Given this list of marker genes Chst2 (NCBI Gene Id 54371), Prokr2, Trim33, Ccl25, Nedd4, Acvr2a, Galnt7, Maml1, St3gal2, Zrsr2, Krtap4-2, Elavl3, Cabp5, Ints8, Ccr1, Stimate, Hmmr, Ttll3, Srf, Ppp1r9b, Nemp1, Zfp462 (zinc finger protein 462), Cd37, Galnt13, Apex2, Slc39a13, Cacna2d2, Clip3, Zfp687, Ahnak, Adtrp, Arb2a, Stk35, Nxph1, Efnb1, 4921517D22Rik, Pik3ca, Dennd4a, here is a description of the gene set: from publication Chen Y, Wang X (PMID 31504780) Genes predicted to be targets of miRBase v22 microRNA mmu_miR_6928_5p in miRDB v6.0 with MirTarget v4 prediction scores > 80 (high confidence targets). Mouse Gene Set: MIR_6928_5P studied in species Mus musculus